Given this list of marker genes Mtr, Dido1, Syncrip, Prlr, Ets2, L2hgdh, Ski, Kcns2, Map3k7, Ptprr, Fbxo43, Foxj3, Gm5591, Arhgap12, Knstrn, Snrpd1, Kcnd3, Cep57, Drd5 (dopamine receptor D5), Reps2, Slc9a6, Ugdh, Scn3a, Mrc1, Il22, Marveld2, Bcor, F2rl1, Arhgap20, Ralgapa2, Igsf9b, Mettl21a, Nsd3, Ube2e3, Hspa4, Flvcr2, Kmt2e, Pgrmc1, Lhx3, Elp4, Rps27l, Zscan20, Tut4, 1700066M21Rik, Dst (NCBI Gene Id 98718), Osbpl8, Sorbs2, Gapt, G3bp2, Apoo, Zfp329, Or52n4, Pola1, Nfkbiz, Rnf115, Extl2, Ikzf1, Gja6, Sestd1, Gm57852, Manea, Trio (triple functional domain (PTPRF interacting)), Lipo2, Brd3, Epm2aip1, Ano5, Kdm1b, Septin8, Spef2, Rab10, Sybu, Eef1d, Tsc22d1, Dsc2, Il22b, Ebf2, Prpf39, 3110040N11Rik, Olr1, Bicd1, Gabrb1, Tbc1d23, Cops5, D630045J12Rik, here is a description of the gene set: studied in species Mus musculus Mouse Gene Set: MIR_1936 Genes predicted to be targets of miRBase v22 microRNA mmu_miR_1936 in miRDB v6.0 with MirTarget v4 prediction scores > 80 (high confidence targets). from publication Chen Y, Wang X (PMID 31504780)